The following is a description of a gene set: Dendritic cells (DCs) are the sentinels of the mammalian immune system and they undergo a complex maturation process mediated by activation upon pathogen detection. Recent studies described the analysis of activated DCs by transcriptional profiling, but translation regulation was never taken in account. Therefore, the nature of the mRNAs being translated at various stages of DC activation was determined with the help of translational profiling, which is the sucrose gradient fractionation of polysomal-bound mRNAs combined to microarrays analysis. Total and polysomal-bound mRNA populations were compared in immature (0h) and LPS-stimulated (4h and 16h) human monocyte-derived DCs with the help of Affymetrix microarrays. Biostatistical analysis indicated that 296 mRNA molecules are translationally regulated during DC-activation. The most abundant biological process among the regulated mRNAs was protein biosynthesis, indicating the existence of a negative feedback loop regulating translation. Interestingly, a cluster of 17 ribosomal proteins were part of the regulated mRNAs, indicating that translation may be fine-tuned by particular components of the translational machinery. Our observations highlight the importance of translation regulation during the immune response, and may favour the identification of novel gene clusters or protein networks relevant for immunity. Our study also provides information on the possible absence of correlation between gene expression and real protein production in DCs. studied in species Homo sapiens Human Gene Set: GSE14000_TRANSLATED_RNA_VS_MRNA_DC_UP Genes up-regulated in comparison of polysome bound (translated) mRNA versus total mRNA in dendritic cells. from publication Ceppi M, Clavarino G, Gatti E, Schmidt EK, de Gassart A, Blankenship D, Ogola G, Banchereau J, Chaussabel D, Pierre P (PMID 19943945), and this is the list of marker genes: MRPL16, PDCL, FOXRED1, RTP4, TFDP3, FOCAD, PDIA5, EBNA1BP2, PSMD12, MRPS28, AKR7A2 (aldo-keto reductase family 7 member A2), MRPS23, POLR2G, NSUN3, HIRIP3, BAG3, ZWINT, YARS2, ACTR3 (NCBI Gene Id 10096), PGM2, TFG, DUSP11, EIF3J, FANCB, DDX55, HMCES, TARS1, NDUFA12, GART, TWNK, MPLKIP, ALG2, GRSF1, PEX14, ACP3, OAT, BUD13, ARGLU1, ANKRA2, SPOUT1, ZNF112, CALM2, WDR20, TTF2, ARID1A, PRPF38A, HAUS8, C8orf76, PPP1R7, AARSD1, EMG1, IARS1, SNRPB2, SAP30BP, GAR1, FAHD1, RRP15, ASH2L, PSMD14 (proteasome 26S subunit, non-ATPase 14), RPL26L1, ACD, RAB11A, DBR1 (NCBI Gene Id 51163), SCRIB, RFC3, SPDL1, DTNBP1, SAP18, LARP1B, N6AMT1, TBCC (NCBI Gene Id 6903), ACTL6A, KAT5, EPS8, MED26, ARHGEF3, ELP4 (NCBI Gene Id 54515), EHHADH, RIOX1, PSMA2 (proteasome 20S subunit alpha 2), CDC73, ANKHD1, NDUFA6, NUP107 (nucleoporin 107), MCM6, WBP4, BEST4, PTCD3, PFDN4, RINT1, EIF4E, MCTS1, TRMO, GSPT2, TMEM199, TEFM, NDUFA8, VPS33A, ZSCAN18, SARNP, SNRPA1, MRPL46, WHAMM, EIF2B3, IFT70B, WRN, CBR4, CEP76, PSMA3 (NCBI Gene Id 5684), BBS10, TSPYL5, PSMB1, PLEKHM3, DCAF13, SAE1 (SUMO1 activating enzyme subunit 1), RIOK1, INPP5F, UCHL5, PTGR1, MPHOSPH6, LDHA, MTM1, EXOSC8, RBM6, CRAMP1, ATP6V1E1, ANKZF1, HIF1AN, PGAM1, POLR1F, MRPS31, AKAP8, EIF2S1, PGM3, DDX39A, KCTD7, ZNF326, STK17A (serine/threonine kinase 17a), COX11, NAT1, OSBPL9, GORAB, TXNDC9, MRPS5, TTC4, BCS1L, HAUS7, KDM2B, MRPL32, RBM12, EIF2B5, SMYD3, PSMA6, NAT10, XRCC4, POLR1B, RAE1, ICA1, FTO, MRPL13, NAF1, MRPL47, PTGER4, PRDX6, CDK5RAP1, MED27 (NCBI Gene Id 9442), PATL1, UTP11, RBM34, MCEE, ACSL1, SUPV3L1, NOL4L, NECAP1, POLR3E, U2AF2, GBE1, PJA1, DNAJA3, ARFGAP3, RHOBTB3, PSMD11, ZC3HC1, NOP2, NXF1, RACGAP1, NIP7, MNAT1, TRAPPC6A, NUSAP1, CETN3, GRPEL1, SMARCAD1 (SWI/SNF-related, matrix-associated actin-dependent regulator of chromatin, subfamily a, containing DEAD/H box 1), CTPS2, PDE8A, CORO1C, FOXK1, DCTN6, ATP6V1C1, NDUFAF1